Given this list of marker genes Rinl, Zfp57, Il17re, Sapcd1, BC028528, Htr3a, Nos3, Art5, Glmp, Slc5a11, Eno3, Phyhd1, Mrgprf, Slc13a2, Igfals, Rhbdf2, F2, Doc2g, Cd68, Fam25a, Rnf151, Ebi3, Robo4, Mip (major intrinsic protein of lens fiber), Mrps21, Cyp2j6 (cytochrome P450, family 2, subfamily j, polypeptide 6), Soat2, Gulo, Slc39a4, Grifin (galectin-related inter-fiber protein), Arhgap27, Fut2 (NCBI Gene Id 14344), Tapbpl, Arhgef11, Slc4a9, F5, Acot11, Gimap5, Art1, Spi1, Nppb, Aspg, Pmel, Dapk3 (NCBI Gene Id 13144), Mab21l3, Dlgap3, Arhgef19, Folr1, Hvcn1, Syne4, Gpr173, Slc12a8, Hacd4, Atp1a2, Gpr20, Prr15l, Tspan32, Sipa1l3, Dab2ip, Fbxw10, Mgat4e, Ccdc121, Ccdc120, Serpinf1, Tnfsf13, Timp4, Scn2b, Rab25, Emp3 (NCBI Gene Id 13732), 2900026A02Rik, Treml2, 4930451I11Rik, Emilin1, Apobr (apolipoprotein B receptor), Spon2, Tmem268, Spef2, Fbxo39, Muc1, Unc13d, Ddr1, Nr0b2, Tnks1bp1, Tns2, Pinlyp, Angptl2, Cab39, Nlrc3, Bpifb5, Cysrt1, Cldn19, Slc16a5, Glrx, 1700010I14Rik, Nxnl1, Itga2b, Mylpf, Sult5a1, Hexim2, P2rx6, Pipox, Cyp4f13, Zmym2, Prtn3, Kcnip3, Masp2, Pirt, Pstpip1 (NCBI Gene Id 19200), Cd79b, Gpsm3, Tmem248, Vwa5a, Hsd17b14, Mmrn2, Tas1r1, Clstn3, Ggnbp1, 2610528J11Rik, Ecrg4, Oprk1, Klhdc7a (NCBI Gene Id 242721), Lrcol1, Selplg, Tbc1d10c, Susd2, Tm4sf5, Fgd4, Ankrd2, Aldh3b1, Exoc3l, Bnipl, Notch4, Dnajb5, Trim21, Pklr, Nyap1, Cox7a1 (NCBI Gene Id 12865), Styxl2, 6820408C15Rik, Cdk3, Aspdh, Ggt6, Ifitm1, Septin1, Vwa3a, Trex1 (NCBI Gene Id 22040), Fgf1, here is a description of the gene set: Genes with low-CpG-density promoters (LCP) bearing histone H3 trimethylation mark at K4 (H3K4me3) in embryonic stem cells (ES). from publication Mikkelsen TS, Ku M, Jaffe DB, Issac B, Lieberman E, Giannoukos G, Alvarez P, Brockman W, Kim TK, Koche RP, Lee W, Mendenhall E, O'Donovan A, Presser A, Russ C, Xie X, Meissner A, Wernig M, Jaenisch R, Nusbaum C, Lander ES, Bernstein BE (PMID 17603471) We report the application of single-molecule-based sequencing technology for high-throughput profiling of histone modifications in mammalian cells. By obtaining over four billion bases of sequence from chromatin immunoprecipitated DNA, we generated genome-wide chromatin-state maps of mouse embryonic stem cells, neural progenitor cells and embryonic fibroblasts. We find that lysine 4 and lysine 27 trimethylation effectively discriminates genes that are expressed, poised for expression, or stably repressed, and therefore reflect cell state and lineage potential. Lysine 36 trimethylation marks primary coding and non-coding transcripts, facilitating gene annotation. Trimethylation of lysine 9 and lysine 20 is detected at satellite, telomeric and active long-terminal repeats, and can spread into proximal unique sequences. Lysine 4 and lysine 9 trimethylation marks imprinting control regions. Finally, we show that chromatin state can be read in an allele-specific manner by using single nucleotide polymorphisms. This study provides a framework for the application of comprehensive chromatin profiling towards characterization of diverse mammalian cell populations. Mouse Gene Set: MIKKELSEN_ES_LCP_WITH_H3K4ME3 studied in species Mus musculus